Given this list of marker genes CDC7, AFAP1 (NCBI Gene Id 60312), ETV1, KYNU, FGL1, KRT9, PLCH1, MFAP1, WSCD2, CXCR4 (C-X-C motif chemokine receptor 4), ANP32A, FABP3, ACRV1, EIF4B, TASOR, BDKRB1, STIM1, NDUFS2, SUMO4, SV2A, CBFA2T3, ENO2, CASP1, PSMC5, NCOA1, CYB561, ODF2, SLC31A2, ZNF75D, KDM4B, TRPV6, MRC2, BTK, MYB, RNF40, GNLY, RUNDC3A, BBS4, MPHOSPH8, CDC42, LYPD1, CEP170B, NCKAP1L, VSIG4, PRP4K, ZFP36L1, TRIM14 (NCBI Gene Id 9830), MAP3K10, BAMBI, PIP5K1C, LINC01587, GBX2, TXNIP, PPBPP2, KCNIP4, ATP6V1E1, ENTPD1, ARNT2, NBEAL2, ADM, CACNB1, JMJD1C, DAAM2, SLC1A3, GUCY1A2, PSMC1, H1-4, ATG4A, CDKN2D, TARDBP (TAR DNA binding protein), RETREG3, FAF2, MEGF8, SF3B1 (splicing factor 3b subunit 1), GGA2, KRIT1, UBE2L3, S100A11, RHOBTB3 (NCBI Gene Id 22836), LAMTOR5, VAMP8, CSN2, FERMT2, PLK2, MRE11, MYRIP, MISP, RRM1, JADE3, DNAJC8, ERG, CETN3, CHD3, ETV5, CASC3 (CASC3 exon junction complex subunit), PRPSAP1, FGF4, IDH1, APOBEC2, PPP1R26, SPOP, PIK3CG, IFITM1, FABP6, ALDH1B1, ZNF460, DHFRP3, FDPS, CHEK1, PFKFB1, IFT70A, C3AR1, KIN, MLH1 (NCBI Gene Id 4292), DNAH7, PKLR, GSE1, CKAP5, RGS2, TP53I11, MCM3, LRP3, RBPMS, UCP2, CECR7, PNP, IFNG, AHCYL1, ABCB7, LDHA, COASY, MLH3, STT3A (STT3 oligosaccharyltransferase complex catalytic subunit A, NCBI Gene Id 8071), FAM169A, MTAP (NCBI Gene Id 8008), LRRN2, VDAC3, EXO1, USH2A (usherin), BAAT, MS4A1, ADGRG6, SORBS2, SRRM2, NSDHL (NAD(P) dependent steroid dehydrogenase-like), DAP3, PGAM1, CLDN7, ARHGEF16, SETD3, GNPDA1, PSMB7, HNRNPA1, C1orf105, CHPF, SLC1A4, PDZK1, ITPKC, PPP4R1, NEDD4L, MLEC, IL5 (interleukin 5), SYCP2, GABARAP, ENSA, AGAP2, KRT16, CDC14B, NTS, PSMA5, UTP20, LSP1, ADIPOR2, BLM, GANAB, CRTAM, BAZ2B, AMELY, STOM, SMCHD1 (NCBI Gene Id 2490), DAD1, AP2B1, KRT75, GLUL, MSTN, ATP2C1, TUSC3, RAB29 (RAB29, member RAS oncogene family), FEM1C, CA4, RNF103, STAB1, CBX5, HSD11B2, ZNF217, CLK1, RBM6, here is a description of the gene set: Genes up-regulated in comparison of dendritic cells (DC) versus DCs exposed to B. malayi (50 worms/well). species: Homo sapiens Monocyte-derived dendritic cells (DC) and macrophages (MΦ) generated in vitro from the same individual blood donors were exposed to five different pathogens, and gene expression profiles were assessed by microarray analysis. Responses to Mycobacterium tuberculosis and to phylogenetically distinct protozoan (Leishmania major, L. donovani, Toxoplasma gondii) and helminth (Brugia malayi) parasites were examined, each of which produces chronic infections in humans yet vary considerably in the nature of the immune responses they trigger. from publication Chaussabel D, Semnani RT, McDowell MA, Sacks D, Sher A, Nutman TB (PMID 12663451) Human Gene Set: GSE360_CTRL_VS_B_MALAYI_HIGH_DOSE_DC_UP